Given this list of marker genes EBP, ATOH7, COL18A1, HMX1 (NCBI Gene Id 3166), DPYD, LAMB2, EPG5, SLC45A2, NDP, MPDZ, PAX6, LYST, HPS6, MAF, FZD4, here is a description of the gene set: Macular hypoplasia Underdevelopment of the macula lutea. Human Gene Set: HP_MACULAR_HYPOPLASIA species: Homo sapiens